The following is a description of a gene set: studied in species Mus musculus Genes with promoters bound by FOXP3 and which are down-regulated both in developing (located in the thymus) and mature (from peripheral blood) regulatory CD4+ T lymphocytes. Mouse Gene Set: ZHENG_FOXP3_TARGETS_DN from publication Zheng Y, Josefowicz SZ, Kas A, Chu TT, Gavin MA, Rudensky AY (PMID 17237761) Transcription factor Foxp3 (forkhead box P3), restricted in its expression to a specialized regulatory CD4+ T-cell subset (T(R)) with a dedicated suppressor function, controls T(R) lineage development. In humans and mice, Foxp3 deficiency results in a paucity of T(R) cells and a fatal breach in immunological tolerance, causing highly aggressive multi-organ autoimmune pathology. Here, through genome-wide analysis combining chromatin immunoprecipitation with mouse genome tiling array profiling, we identify Foxp3 binding regions for approximately genes and for an intergenically encoded microRNA. We find that a large number of Foxp3-bound genes are up- or downregulated in Foxp3+ T cells, suggesting that Foxp3 acts as both a transcriptional activator and repressor. Foxp3-mediated regulation unique to the thymus affects, among others, genes encoding nuclear factors that control gene expression and chromatin remodelling. In contrast, Foxp3 target genes shared by the thymic and peripheral T(R) cells encode primarily plasma membrane proteins, as well as cell signalling proteins. Together, our studies suggest that distinct transcriptional sub-programmes implemented by Foxp3 establish T(R) lineage during differentiation and its proliferative and functional competence in the periphery., and this is the list of marker genes: Znrf1, Sptbn1, Pde3b, Phxr4, Tbc1d4, Ms4a4c, Gpd2, Dapl1